The following is a description of a gene set: Genes in the cancer module 77. Human Gene Set: MODULE_77 species: Homo sapiens, and this is the list of marker genes: NDUFB5, NDUFB1, NDUFAB1, NDUFC1, NDUFS5, NDUFB3, NDUFA9, NDUFA4, NDUFB7, NDUFA7, NDUFB8, UQCRC2, UQCRB, NDUFS6, NDUFV1, UQCRC1, NDUFA2, NDUFV2, NDUFB10, NDUFA1, PRMT1, NDUFA5, NDUFA3, NDUFS3, N6AMT1, NDUFS4, NDUFS2, NDUFS8